Given this list of marker genes PPP1CB, NDC80, PPP1CA, SKA1, TTK, AURKB, SPC25, NUF2, PPP1CC, SKA2, SKA3, SPC24, here is a description of the gene set: studied in species Homo sapiens Pathway Definition from KEGG: NDC80C == (SKA1+SKA2+SKA3) == PP1 -| (MPS1,AURKB) Dephosphorylation of kinetochore. Pathway ID: N01536. Pathway type: Reference. Pathway class: nt06515 Regulation of kinetochore-microtubule interactions. Human Gene Set: KEGG_MEDICUS_REFERENCE_DEPHOSPHORYLATION_OF_KINETOCHORE